Given this list of marker genes MAP1A, VPS35, VTI1A, MTOR, HIPK2, ITPR1, here is a description of the gene set: studied in species Homo sapiens The movement of an organism or part of an organism using mechanoreceptors, the nervous system, striated muscle and/or the skeletal system that can be controlled at will. Human Gene Set: GOBP_VOLUNTARY_MUSCULOSKELETAL_MOVEMENT